Given this list of marker genes Lsp1, Emp3, Ubc, Celf2, Cox7a2l, Igf1r, Il7r, Ahnak, Tnik, Txnip, Rhob, Jun, Btg2, Ckb, Hspa1b, Lgals9, Tspo, Fosb, Evl, Pnrc1, Cxcr4, Ptpn18, Faah, Dnaja1, Lmo4, Ramp3 (NCBI Gene Id 56089), Plgrkt, Rsrp1, Il17rb, Zfp36l2, Hspa1a, S100a10, Smpdl3a, Ucp2, Klf6, Tmem64, Rnf144a, Rgs2, Fos, Itm2b, Aak1, Crlf3, Ltb, Nr4a1, Rgcc, Neurl3, Foxp1, Thy1, Akap13, Crip1 (NCBI Gene Id 12925), Shisa5, Klf2, Sdc1, Actn2, here is a description of the gene set: Mouse Gene Set: CUI_T_CELL_GD_IL23_RESPONSE_DN species: Mus musculus from publication Cui A, Huang T, Li S, Ma A, Pérez JL, Sander C, Keskin DB, Wu CJ, Fraenkel E, Hacohen N (PMID 38057668) Genes negatively differentially expressed in cell type: γδ T cell upon treatment with cytokine: IL-23 in mouse lymph nodes in vivo. Cytokines mediate cell-cell communication in the immune system and represent important therapeutic targets. A myriad of studies have highlighted their central role in immune function, yet we lack a global view of the cellular responses of each immune cell type to each cytokine. To address this gap, the authors created the Immune Dictionary, a compendium of single-cell transcriptomic profiles of more than 17 immune cell types in response to each of 86 cytokines (>1,400 cytokine-cell type combinations) in mouse lymph nodes in vivo. A cytokine-centric view of the dictionary revealed that most cytokines induce highly cell-type-specific responses. For example, the inflammatory cytokine interleukin-1β induces distinct gene programmes in almost every cell type. A cell-type-centric view of the dictionary identified more than 66 cytokine-driven cellular polarization states across immune cell types, including previously uncharacterized states such as an interleukin-18-induced polyfunctional natural killer cell state.